The following is a description of a gene set: We identified Pparg as a major orchestrator of the phenotype of adipose-tissue resident regulatory T cells (VAT Tregs). To explore the contribution of Pparg1 and 2 in the generation of the VAT Tregs-specific gene signatures, CD4+FoxP3- T cells were transduced with Foxp3+/- Pparg1 (or Pparg2), treated with Pioglitazone or vehicle, and double sorted for microarray analysis. Genes up-regulated in CD4 T cells over-expressing FOXP3: untreated versus pioglitazone. studied in species Homo sapiens Human Gene Set: GSE37533_UNTREATED_VS_PIOGLIZATONE_TREATED_CD4_TCELL_FOXP3_TRASDUCED_CD4_TCELL_UP from publication Cipolletta D, Feuerer M, Li A, Kamei N, Lee J, Shoelson SE, Benoist C, Mathis D (PMID 22722857), and this is the list of marker genes: SAMD8, OTULIN, PRKCQ, FAM3B, SH3BP2, FOXJ1 (NCBI Gene Id 2302), PDE4C, GDF5, SPOCK1, LRRTM2, AIF1L, EYA1, CDHR5, NOMO1, HMOX1, TEX15, UNC5D, CARS1, MUCL1, ATAD2B, STING1, CDH17, WDR72, TBX4, IL17F, ST6GALNAC4, LY6G6F, TMEM72, PSME1, TTR, TRPC5, FLRT3, MAOA, APCDD1, DNAJB11, IER3, PRODH, RIC1, JAGN1, GPR155, SUZ12, LCN10, VPS54, RPF2, MRPL46, BCAP29, SPIRE1, UBFD1, NAB1, PABPC4, SELENOI, SRPRA, TOMM5, NCCRP1 (NCCRP1, F-box associated domain containing), SYNCRIP, FGGY, NAGS, TNFAIP8 (TNF alpha induced protein 8), WARS1, PXT1, DCTD, NOB1, TRMT61A, SPMIP7, SEC11C, PRDM2, PPP1R14D, SLC38A8, DMRT3, HAX1, PINLYP, RSPH9, CIAPIN1, H1-7, GPR84, SRPK3, DLG5, UTP23, RPS8, NDUFA12, OPRD1, RBPJ, CNP, PGAP2, SLC25A33, TBC1D1, LUZP1, CXCL9 (C-X-C motif chemokine ligand 9), IL18 (NCBI Gene Id 3606), SLFNL1, HNRNPA0, HRAS, COL5A3, TCF4, RGS20, C1GALT1C1, RAB20, SUMO2, NUPR1, MRPL11, TNKS1BP1, PKM, HLA-B, KCNC3, PTPN13, RBBP8NL, TMEM185B, HR, TGFB1, MYL12A, SMOX, MIR24-2 (NCBI Gene Id 407013), NEFL, PSMA2, ZDHHC21, DNAJC25, EPRS1, SIM2, PMPCA, TGIF2 (TGFB induced factor homeobox 2), TLCD5, PUM2, LDLRAD2, NUP107, TGS1, VWC2, HYCC1, EFNA4 (ephrin A4), MORN1, CCDC124, SERPINE1, SEC23B, COX18, ME1, ADAP1, SLC16A12 (NCBI Gene Id 387700), SFXN1, COL6A4P1, GREP1, ALX3, SELENOT, TFEC, CSE1L, PLOD2, GASK1B, LACTBL1, XBP1, PWP2, NSRP1, TBRG4, INPP5A (NCBI Gene Id 3632), FYB1, TNFSF4, SIGLEC15, PLAA, ANO3, EIF2B5 (eukaryotic translation initiation factor 2B subunit epsilon), SPHK1, POLR1B, TMA16, CLTB, THBS2, IER5, STK39, EIF6, RNF11, CPEB3, DHX15, STMN3, LSMEM2